The following is a description of a gene set: Binding to a membrane and increasing its permeability. This may lead to cell membrane lysis and cell content release. Human Gene Set: GOMF_MEMBRANE_DESTABILIZING_ACTIVITY species: Homo sapiens, and this is the list of marker genes: NINJ2, DEFB118 (NCBI Gene Id 117285), LTF, NINJ1, MROH1